The following is a description of a gene set: Reactome Pathway: Binding and Uptake of Ligands by Scavenger Receptors part of: Vesicle-mediated transport studied in species Homo sapiens Scavenger receptors bind free extracellular ligands as the initial step in clearance of the ligands from the body. Some scavenger receptors, such as the CD163-haptoglobin system, are specific for only one ligand. Others, such as the SCARA receptors (SR-A receptors) are less specific, binding several ligands which share a common property, such as polyanionic charges.<br>Brown and Goldstein originated the idea of receptors dedicated to scavenging aberrant molecules such as modified low density lipoprotein particles and such receptors have been shown to participate in pathological processes such as atherosclerosis. Based on homology, scavenger receptors have been categorized into classes A-H., and this is the list of marker genes: LRP1, IGLC1, IGKV2-29, IGLV3-22, MASP1, IGLV5-45, IGLV3-25, IGHV4-59, IGKV1D-12, SCGB3A2, COL4A1, SCARA5, JCHAIN, IGLV10-54, FTH1, IGLV2-8, HSP90AA1, CD5L, IGKV2D-30, IGLV6-57, IGLV, STAB2, HPR, IGKV1-39, HP, FTL (ferritin light chain), IGHV1-69, COL3A1, IGKV1D-33, APOA1, IGKV4-1, SAA1, IGKV3-20, IGKV1D-16, IGHV1-46, IGKV2-30, IGLV3-16, IGLV4-3, ALB, COL1A2, HSP90B1, IGKV2D-40, HMGB1, HYOU1, IGLV3-1, IGLV3-12, IGKV1-33, IGKC, IGHV3-9, IGHV3-7 (NCBI Gene Id 28452), IGLV2-18, IGKV1-17, COL1A1, IGHV3-33, IGLV2-23, HPX, SCARF1, IGLV3-19, IGKV3D-20, IGLV3-27, porB, CALR, IGLV1-36, IGHV3-11, IGHV3-48, IGKV5-2, IGKV3-15, IGHV, IGLC7, IGKV1-12, IGLV8-61, APOL1, PRDX1, IGLV2-14, IGHV1-2, AMBP, IGLV7-43, IGHV3-13, MSR1, APOE, IGHV3-30, IGHV4-39, APOB, IGKV2-28, IGHV3-53, IGLV1-40, HBB, IGLV7-46, IGKV1-5, IGLC2, IGLC3, S100A9, IGLV1-44, IGKV2D-28, IGHA2 (immunoglobulin heavy constant alpha 2 (A2m marker)), COL4A2, IGLC6, STAB1, IGLV5-37, IGHA1, SPARC, CD36, SSC5D, HSPH1, IGLV2-11, CD163, IGLV2-33, IGHV3-23, HBA1, IGLV1-47, IGKV3-11, SCARB1, IGHV2-5, IGHV4-34, IGLV1-51, IGHV7-81, MARCO, IGKV1-16, IGLV4-60, IGLV11-55, IGLV4-69, IGHV2-70, COLEC11, IGLV3-21, IGKV1D-39, COLEC12